Given this list of marker genes Chrna7, Sp8 (trans-acting transcription factor 8), Gm23445, Fam241b, Hoxd3os1, Prtg, Doc2a, Irx3, Crabp2, Rpl28, A730062M13Rik, Sfrp2, Ogdhl, Sall4, Fzd7, Scube2 (signal peptide, CUB domain, EGF-like 2), Zfp617, Gm30698, Sox21os1, Foxb1, Slc2a1, Repin1, Slain1os, Ndnf (neuron-derived neurotrophic factor), Greb1, 5430402O13Rik, here is a description of the gene set: from publication Cao J, Spielmann M, Qiu X, Huang X, Ibrahim DM, Hill AJ, Zhang F, Mundlos S, Christiansen L, Steemers FJ, Trapnell C, Shendure J (PMID 30787437) Mouse Gene Set: DESCARTES_ORGANOGENESIS_NEURAL_TUBE species: Mus musculus Mouse Organogenesis Cell Atlas (MOCA) DE_gene_main_cluster.csv, fold.change>=1.5, qval<0.05, pval<0.05